The following is a description of a gene set: Pathway Definition from KEGG: (NPRL2+NPRL3+DEPDC5) -| (RRAGA+RRAGB+RRAGC+RRAGD) -> mTORC1 species: Homo sapiens Human Gene Set: KEGG_MEDICUS_REFERENCE_GATOR1_MTORC1_SIGNALING_PATHWAY GATOR1-mTORC1 signaling pathway. Pathway ID: N01578. Pathway type: Reference. Pathway class: nt06522 mTOR signaling., and this is the list of marker genes: TTI1, DEPDC5, RRAGA, DEPTOR, RRAGD, RPTOR (regulatory associated protein of MTOR complex 1), TELO2, NPRL2, MTOR, RRAGC, RRAGB, MLST8, NPRL3, AKT1S1